Given this list of marker genes Ccl21e, Myd88, Il23a, Prkca, Camk1d, Spp1, Zpld2 (zona pellucida like domain containing 2), Prtn3, Itga9, Rac3, Ccl21d, Xcl1, Prex1, Cxcl3, Fcgr3, Mdk, Dysf, Cxcl9, Ccl2, Pawr, Ptger3, Ppbp, Tlr2, Syk, Ppib, Rtn4, Csf3r, Mcoln2, Edn3, Cxcl5, C1qbp, C5ar1, Adam8, Nckap1l, Tnfaip6, Sell, Dnm1l, Ripor2, Slc37a4, S100a9, Fut7, Tgfb2 (transforming growth factor, beta 2), Edn2, Ptger4, Bst1, Dpep1, Wdr1, Ccl19-ps1, Cd74, Dpp4, Fcer1g, Cklf, Cxcl10, Ccl19-ps6, Gbf1, Ccl28, Fam3d, Cxcl15, Cxadr, Jam3, Nod2, Il17b, Cd99l2, Pde4b, Pde4d, Tirap, Trem3, Ednra, Itgam, Slamf8, Bsg, Cxcr2, Lgals3, Cxcr1, Ccl19-ps4, Thbs4, Edn1, Ifng, Dapk2, Ccl21b, Myo1f, Lbp, Mospd2, Rac2, Itga1, Mcu, Ccr7, Selenok, Ccl3, Gm5849, Mpp1, Itgb2l, Pf4, C5ar2, Vav1 (vav 1 oncogene), Emp2, Ppia, Srp54a, Pecam1 (platelet/endothelial cell adhesion molecule 1), Trem1 (NCBI Gene Id 58217), Cxcl2, Rac1, Irak4, Cd177 (CD177 antigen), Il1b (interleukin 1 beta), Jagn1, Ccl21a, Fut4, Il1a (interleukin 1 alpha), Cx3cl1, Itgb2, Pikfyve, Jaml, Ccl19-ps3, Ccl19-ps5, Ccl21f, Ccl27a, Vav3, S100a8, Slit2, Cxcl1, Umod, Il1r1, Perp, Ccl19, Cxcl13, Gp2, C3ar1, here is a description of the gene set: studied in species Mus musculus The movement of a neutrophil within or between different tissues and organs of the body. Mouse Gene Set: GOBP_NEUTROPHIL_MIGRATION